Given this list of marker genes BNC2, AVPR2, RNF168, KY, AQP2, FA2H, ZMYM3, SLC5A2, FOXP2, ADNP, BMP1, PRKAR1B, here is a description of the gene set: Enuresis nocturna species: Homo sapiens Enuresis occurring during sleeping hours. Human Gene Set: HP_ENURESIS_NOCTURNA